Given this list of marker genes SLC8A2, SLC24A5, SLC8B1, SLC8A3, SLC24A2, SLC24A1, SLC24A4 (solute carrier family 24 member 4), SLC24A3, SLC8A1, here is a description of the gene set: Human Gene Set: GOMF_CALCIUM_SODIUM_ANTIPORTER_ACTIVITY studied in species Homo sapiens Enables the transfer of a solute or solutes from one side of a membrane to the other according to the reaction: Ca2+(in) + Na+(out) = Ca2+(out) + Na+(in).